Given this list of marker genes AGT, WASF1, DOK5, ZDHHC17, PPP2R5B, SPRY2, SPRY1, TMEM108, CYFIP2, CYFIP1 (cytoplasmic FMR1 interacting protein 1), AGTR2, here is a description of the gene set: studied in species Homo sapiens Any process that modulates the frequency, rate or extent of the neurotrophin TRK receptor signaling pathway. Human Gene Set: GOBP_REGULATION_OF_NEUROTROPHIN_TRK_RECEPTOR_SIGNALING_PATHWAY